The following is a description of a gene set: studied in species Homo sapiens Reactome Pathway: Blood group systems biosynthesis part of: Metabolism of carbohydrates and carbohydrate derivatives The association between blood type and disease has been studied since the beginning of the 20th Century. Landsteiner's discovery of blood groups in 1900 was based on agglutination patterns of red blood cells when blood types from different donors were mixed. His work is the basis of routine compatibility testing and transfusion practices today. The immune system of patients receiving blood transfusions will attack any donor red blood cells that contain antigens that differ from their self-antigens. Therefore, matching blood types is essential for safe blood transfusions. Landsteiner's classification of the ABO blood groups confirmed that antigens were inherited characteristics. In the 1940s, it was established that the specificity of blood group antigens was determined by their unique oligosaccharide structures. Since then, exponential advances in technology have resulted in the identification of over 300 blood group antigens, classified into more than 35 blood group systems by the International Society of Blood Transfusion (ISBT).<br><br>Blood group antigens comprise either a protein portion or oligosaccharide sequence attached on a glycolipid or glycoprotein. The addition of one or more specific sugar molecules to this oligosaccharide sequence at specific positions by a variety of glycosyltransferases results in the formation of mature blood group antigens. The genes that code for glycosytransferases can contain genetic changes that produce antigenic differences, resulting in new antigens or loss of expression. Blood group antigens are found on red blood cells (RBCs), platelets, leukocytes, and plasma proteins and also exist in soluble form in bodily secretions such as breast milk, seminal fluid, saliva, sweat, gastric secretions and urine. Blood groups are implicated in many diseases such as those related to malignancy (Rummel & Ellsworth 2016), the cardiovascular system (Liumbruno & Franchini 2013), metabolism and infection (Rios & Bianco 2000, McCullough 2014). The most important and best-studied blood groups are the ABO, Lewis and Rhesus systems. The biosynthesis of the antigens in these systems is described in this section., and this is the list of marker genes: FUT9, B3GALT4, B4GALNT2, FUT6, FUT7, FUT2, ABO, FUT4, ST3GAL4, ST6GALNAC6 (ST6 N-acetylgalactosaminide alpha-2,6-sialyltransferase 6), B3GALT5, FUT3 (NCBI Gene Id 2525), ST3GAL3, ST3GAL6, B3GALT1, FUT5, RHD, B3GALT2, FUT1, RHCE